Given this list of marker genes CALML5, TEX26-AS1, ADAM7 (NCBI Gene Id 8756), CMTM2, METAP1D, PNLIPRP1, CSF2RA, CDK20, LINC00954, EPM2AIP1, LINC01193, SEMA3A, PLA2G2D, HOXD3, VPS37D, MED15, NKAPL, MBNL1-AS1 (NCBI Gene Id 401093), OASL, CAMKV, CBLIF, PDE1A, DEFB123, AP2A1, APOL1, PITPNA-AS1, SCGB1A1 (secretoglobin family 1A member 1), XPNPEP3, SH3BGR, SPAM1, LINC03122, SFT2D3, PMS2P4 (PMS1 homolog 2, mismatch repair system component pseudogene 4), SPINK13, NECAB1, CABLES1, PABIR2, SRR, NALF1, LYZL6, CDC6, OR8B8, PCDHA2, TMEM253, ACTN3, NEDD1, GSK3A, PURA, SERPINB3, C14orf178, LINC01931, RAD21-AS1, CCKBR (cholecystokinin B receptor), SLFNL1, USH1G, TUFT1, ANKMY1, GABRG3, TEC, NACAD, MRPL19, WBP2, CFAP74, TRIML1, LINC00996, TYR, RTL8C, POMP, H2AJ, ASS1, SPAG17, MCC, KIR3DS1, FRAS1, PRR5, HTRA1, SLC27A6, GARNL3, REL-DT, SLC13A2, ENTPD4, TBX2, FAM174B, CMPK2, TREML3P, KLK8, DSCAM, MAPK12, LINC00868, ALDH1A3, LINC00919, TGIF2LY, ZNF706, OPALIN, SOX9-AS1, SLC24A3-AS1, EXO1, TBX5, CCDC13-AS1, VWA3A, OR7E24, UBE2QL1, CCN4, DEFB126, RELT, MC3R, GZMB, PIP, TCHH, CARINH, SHISA6, C7orf33, CNR2, LGALS4, MRPL38, TMPRSS6, TBATA, ZSCAN1, HNF1A, TMC2, TSPAN9, ABHD12B, NR0B1, FEZ1, PICSAR, GAS8-AS1, TTTY7, LRTM2, SLC39A5, GATA1, ENSG00000228919, IDI2-AS1, NPTX2, STAB2, TRPC6, ISG15, ZNF407-AS1, TSPYL5, LINC00645, SLC5A9, FAM171A2, URB1-AS1, PHB1P19, TRBV7-3, TPTE2P1, SPRR4, S1PR3, MAPK15, PTPRD, FZD4, FBXL7 (F-box and leucine rich repeat protein 7), ATOH7, ZNF780B, IL1A, ACRV1, MYLK, ANKRD36BP2, ZNF232, SUSD4, KCNK5, KCNG2, BCAS4, KRT8P12, KRTAP4-2, NUDT10, TAB1, CFAP43, CCDC134, FOXD1, GYS2, JPH2, ACSM1, POU6F1, SLC44A1, ZNF295-AS1, XGY2, MAGEC2, ZNF214, ADAP1, FBXL13 (NCBI Gene Id 222235), SLC6A16, ZNF117, GAL3ST1, CLDN16, SH3GLB2, RAB6A, LMO7, SLC13A1, here is a description of the gene set: Genes down-regulated in macrophages (12h): IFNG and TNF versus rosiglitazone. Human CD14 positive monocytes were purified from healthy volunteers’ blood and cultured in vitro for 4, 12, 24, 72 hours. While culturing, macrophages were activated alternatively with interleukin-4 (IL-4 100 ng/ml) or classically with interferon-gamma (IFNg 100 ng/ml)+tumor necrosis factor (TNF 50 ng/ml) or left without activation. Simultaneously, macrophages were also treated with vehicle (DMSO:ethanol) or 1mM synthetic PPARg agonist, Rosiglitazone. We used Affymetrix microarrays (U133Plus 2.0) to analyze activation and PPARg-induced gene expression changes. studied in species Homo sapiens Human Gene Set: GSE16385_IFNG_TNF_VS_ROSIGLITAZONE_STIM_MACROPHAGE_DN from publication Szanto A, Balint BL, Nagy ZS, Barta E, Dezso B, Pap A, Szeles L, Poliska S, Oros M, Evans RM, Barak Y, Schwabe J, Nagy L (PMID 21093321)